Given this list of marker genes ITIH1, MKLN1, SLC14A1, SCAP, MIR200C, B4GALNT3, FAM3D, STXBP2, ZNF446, PALM3, SLC7A8, ZNF655 (zinc finger protein 655), RNF222, BCL7C, MIR141, ENPP6 (NCBI Gene Id 133121), COL5A1-AS1, C3orf70, MIR342, TTLL8, RSPO4, OACYLP (NCBI Gene Id 390858), XG, CPLX1, LINC02846, LINC01613, CTTN-DT, NOP53-AS1, CTF1, C10orf90, YIF1B, ZNF571, TTYH1, BLM (NCBI Gene Id 641), TM4SF1-AS1, ZNF146, SLC26A6, RN7SL443P, NUDT5, TMCO5A, COPS9, GABBR1, UBAP2L, MIR200CHG, PCBP1-AS1, CLK2, AHNAK, TCP10L2, PHF19, GLRA1, UTP6, CRY1 (NCBI Gene Id 1407), KASH5, RN7SKP291, SPAG7, SNORD118, ZNF565, PIANP, ZNF331, ATXN2L, C1orf43, ZNF540, LINC00922, TMEM79, GPBAR1, SCRT2, DPF2, TM4SF1, TMEM108, here is a description of the gene set: from publication Yevshin I, Sharipov R, Kolmykov S, Kondrakhin Y, Kolpakov F (PMID 30445619) Genes containing one or more binding sites for (SKP2) in their promoter regions (TSS -1000,+100 bp) as identified by GTRD version 20.06 ChIP-seq harmonization. studied in species Homo sapiens Human Gene Set: SKP2_TARGET_GENES